The following is a description of a gene set: Reactome Pathway: Signaling by RAS GTPase mutants part of: RAS GTPase cycle mutants This pathway describes RAS mutants with decreased intrinsic GTPase activity that therefore support increased RAS pathway activity. species: Homo sapiens, and this is the list of marker genes: NRAS, HRAS, KRAS